The following is a description of a gene set: From the conditioned medium of the human colon carcinoma cells, HT-29 5M21 (CM-5M21), expressing a spontaneous invasive phenotype, tumor-associated trypsin inhibitor (TATI) was identified and characterized by proteomics, cDNA microarray approaches and functional analyses. Both CM-5M21 and recombinant TATI, but not the K18Y-TATI mutant at the protease inhibitor site, trigger collagen type I invasion by several human adenoma and carcinoma cells of the colon and breast, through phosphoinositide-3-kinase, protein kinase C and Rho-GTPases/Rho kinase-dependent pathways. Conversely, the proinvasive action of TATI in parental HT29 cells was alleviated by the TATI antibody PSKAN2 and the K18Y-TATI mutant. Stable expression of K18Y-TATI in HT-29 5M21 cells downregulated tumor growth, angiogenesis and the expression of several metastasis-related genes, including CSPG4 (13.8-fold), BMP-7 (9.7-fold), the BMP antagonist CHORDIN (5.2-fold), IGFBP-2 and IGF2 (9.6- and 4.6-fold). Accordingly, ectopic expression of KY-TATI inhibited the development of lung metastases from HT-29 5M21 tumor xenografts in immunodeficient mice. These findings identify TATI as an autocrine transforming factor potentially involved in early and late events of colon cancer progression, including local invasion of the primary tumor and its metastatic spread. Targeting TATI, its molecular partners and effectors may bring novel therapeutic applications for high-grade human solid tumors in the digestive and urogenital systems. Genes down-regulated in constitutively invasive HT-29 5M21 cells (colon cancer) vs those expressing functionally inactive TATI. from publication Gouyer V, Fontaine D, Dumont P, de Wever O, Fontayne-Devaud H, Leteurtre E, Truant S, Delacour D, Drobecq H, Kerckaert JP, de Launoit Y, Bracke M, Gespach C, Desseyn JL, Huet G (PMID 18317448) species: Homo sapiens Human Gene Set: GOUYER_TATI_TARGETS_DN, and this is the list of marker genes: LOXL4 (NCBI Gene Id 84171), TAGLN, FABP5 (fatty acid binding protein 5), SNCG, MAPK12, PTP4A3, HPN, CSPG4, IGF2, FN1, TIMP4, BMP7, RBBP8NL, A4GALT, MCAM, S100A4, IGFBP2 (NCBI Gene Id 3485)